Given this list of marker genes NEB, LMNA (NCBI Gene Id 7816), CFL2, FLNC, MT-ATP8, PLIN4, AK9, SIGMAR1, SYNE1, CHRND, MYH7, LAMA2, SNAP25, LAMB2, FUS, NOTCH2NLC, SELENON, COL12A1, COLQ, TGM6, SLC18A3, DES, RRM2B, ALS2, DYSF, MEGF10, COL6A1, POLG, PSAP, SGCG, ORAI1, KBTBD13 (kelch repeat and BTB domain containing 13), AGRN, TRIP4, COL6A3, GMPPB, GALC, KLHL41, VAMP1, MYPN, MORC2, FA2H, JAG2, TRIM32, SCN4A, CNBP, MYO9A, ACTA1, SLC25A1, TMEM43, CHCHD10, DNM2, TNNT1, GYG1, CHAT, TPM2, SPG11, PABPN1, TTN, MTMR14, LRP4, TOP3A, LRIF1, MUSK, CRYAB, PNPLA2, SLC52A3, GFPT1 (NCBI Gene Id 2673), DOK7 (NCBI Gene Id 619409), COL13A1, CHRNA1 (cholinergic receptor nicotinic alpha 1 subunit), PRPS1, SLC5A7, SLC52A2, MT-TL1, TPM3, RNASEH1, LPIN1, MYL1, SPTLC1, MYH2, SLC22A5, CHRNE, CHRNB1, RAPSN, MTM1, LMOD3, CAV3, PYROXD1, SYT2, OBSCN, COL6A2, MT-CO1, ADCY5, MT-CO3, here is a description of the gene set: Neck muscle weakness Human Gene Set: HP_NECK_MUSCLE_WEAKNESS species: Homo sapiens Decreased strength of the neck musculature.